Given this list of marker genes NTRK2, NTF3, here is a description of the gene set: Reactome Pathway: NTF3 activates NTRK2 (TRKB) signaling Neurotrophin receptor tyrosine kinase NTRK2 (TRKB) is a low affinity receptor for neurotrophin-3 (NTF3, also known as NT-3). NTF3 predominantly functions as the ligand for the NTRK3 (TRKC) receptor. Binding to NTF3 can trigger NTRK2 dimerization and trans-autophosphorylation of NTRK2 dimers on conserved tyrosine residues in the cytoplasmic tail of the receptor. The efficacy of this process, however, is low in comparison to NTRK2 activation by BDNF and NTF3, and downstream signaling has not been studied. studied in species Homo sapiens part of: Signaling by NTRK2 (TRKB)